Given this list of marker genes GTF3C5, NOL6 (NCBI Gene Id 65083), RDH10, MRPL54, AUP1, PTGIR, MYF5, P2RY6, CCL13, WDSUB1, SGCB, RMC1 (regulator of MON1-CCZ1), SS18L2, PTBP1, MED20, RNF121, KCTD11, TCF21, TIMP2, SRSF1, P2RY14, LRRC59, RRP8, SEPTIN9, NR4A3, INHBA, BRD2, ATP2B2, TMEM168, RBMS1 (RNA binding motif single stranded interacting protein 1), TAOK3, HLA-DRB1, ISOC1, EPB41L2, MANF, HGF, CBX2, MAPK6, SLC25A25, ZFP82, APBB2, NFE2L2, TCTE1, ATP10A, NAA20, KCNA5, MMP12, WDR82, PMM2, KLRC2, ATG3, TTL (tubulin tyrosine ligase), PLAAT3, ETNK1, ANPEP, DNMT3A, FMR1, SLCO1A2, SDAD1, CALR, CCT7, MAP4K3, UTP20, CD151, KDM5B, H2AC25, SLCO1B3, RAB22A, ACOD1, DEPDC7, GADD45B, ARF4, MRPL11, YY1, BCLAF1, EEF1E1, RPS27L, KATNBL1, CHD1L, MAP2, ARHGAP10, DUSP1, ZUP1, SOCS6, USB1, UCN, NEK6, NECTIN2, MFHAS1, SLC3A2, H2AX, CDKN1A, TBC1D13, EXOC6, KAT2A, PHF23, DOLPP1, S100A8, CBFA2T3, CRYBB3, EIF1AX, HVCN1, DOK1, PLK2, SEPTIN7, ITGB1BP1, SIRT4, CCDC25, MEFV, PRRC1, ICAM1, GOLGA7, SEPTIN11, TMEM9B, CAPN2, FSTL1, OLR1, ACTN1, METTL21A, TUBA1B, VAV1, GNA13, NDUFAF5, KLF17, AEN, CCNJ, UTP18 (UTP18 small subunit processome component), RHOB, IFIT3, NOL12, ZNF207, DR1, BNIP2, PPP1R14B, RRAS2, RHOC, MGLL (NCBI Gene Id 152009), FGR, CLEC10A, GFM1, TMEM129, E2F6, ALCAM, RAN, STAM, S100A6, RBM7, ACVRL1, KRTDAP (keratinocyte differentiation associated protein), CLEC7A, ZBED4, IFITM10, VWA5A, WFDC1 (NCBI Gene Id 58189), SSTR1, EVL, RRP15, CXCL10 (C-X-C motif chemokine ligand 10), CASP7, UBE2F, PRPF38A, SNF8 (SNF8 subunit of ESCRT-II), ITGAX, NME6 (NME/NM23 nucleoside diphosphate kinase 6), MYD88, LSM14B, IGF2BP1, PSMC6 (proteasome 26S subunit, ATPase 6), SRSF9, DUSP3, UBXN2A, KCNJ8, DLX5, ATP6V1G1, NGDN, EEF1G, WNK4, TMEM161A, YIF1A, GEM, KTI12, NAMPT, WRNIP1, QPCT, NT5C3A, KLF10, MOB3B, APOE, NOP58, GPC3, CD84, NGF, MYC, MUC1, PLIN3, QNG1, GRAMD2B, ABHD2, BCL3, F3, here is a description of the gene set: species: Homo sapiens from publication Amit I, Garber M, Chevrier N, Leite AP, Donner Y, Eisenhaure T, Guttman M, Grenier JK, Li W, Zuk O, Schubert LA, Birditt B, Shay T, Goren A, Zhang X, Smith Z, Deering R, McDonald RC, Cabili M, Bernstein BE, Rinn JL, Meissner A, Root DE, Hacohen N, Regev A (PMID 19729616) Genes up-regulated in comparison of dendritic cells (DC) stimulated with Pam3Csk4 (TLR1/2 agonist) at 12 h versus those stimulated with Pam3Csk4 (TLR1/2 agonist) at 24 h. mouse primary BMDCs were stimulated with tlr ligands and gene expression changes were profiled on Affymetrix arrays Human Gene Set: GSE17721_12H_VS_24H_PAM3CSK4_BMDC_UP